Given this list of marker genes Bcl6, Il2, Ddrgk1, Il10, Xbp1, Lilrb4a, here is a description of the gene set: Any process that modulates the frequency, rate or extent of plasma cell differentiation. species: Mus musculus Mouse Gene Set: GOBP_REGULATION_OF_PLASMA_CELL_DIFFERENTIATION